Given this list of marker genes Ank3, Kcna2, Camk2d, Kcna1, Kcnq3, Lrrc7, Adam22, Kcnq2, Scn2b, Cck, Kcnab2, Scn8a, Scn1a, Bcan, Lgi1, Clcn2, Dlg2, Iqschfp, Cnga3, Nav1, Sptbn4, Kcna4, Cntn2, Nfasc, Bin1, Map2, Scn2a, Nrcam, Map1a, Cntnap2, Trim46, here is a description of the gene set: Mouse Gene Set: GOCC_AXON_INITIAL_SEGMENT studied in species Mus musculus Portion of the axon proximal to the neuronal cell body, at the level of the axon hillock. The action potentials that propagate along the axon are generated at the level of this initial segment.